Given this list of marker genes GSTA2, BCO2, CYP2E1, DBP, TTR, AFP, BBOX1, OTOP3, PLSCR1, PPM1J, MCAM, CRP, SLC13A1, GPR151, MPP4, CYP1A1, FOXQ1, APOA2, here is a description of the gene set: Genes down-regulated in small intestine tissue from transgenic mice expressing a mutant form of COL13A1, compared to normal controls. species: Mus musculus from publication Tuomisto A, Sund M, Tahkola J, Latvanlehto A, Savolainen ER, Autio-Harmainen H, Liakka A, Sormunen R, Vuoristo J, West A, Lahesmaa R, Morse HC 3rd, Pihlajaniemi T (PMID 19074901) Human Gene Set: TUOMISTO_TUMOR_SUPPRESSION_BY_COL13A1_DN Epithelial cells of mucosal surfaces are critical for maintaining immune homeostasis by aiding in the discrimination of pathogenic and commensal microorganisms and modulating the activities of antigen-presenting cells and lymphocytes. Functional breakdowns resulting in chronic infection and inflammation are associated with the development of hematologic and solid neoplasms for which detailed pathogenetic mechanisms are poorly understood. Mice heterozygous for a transgene Col13a1(del) expressing a mutant collagen XIII developed clonal mature B-cell lineage lymphomas originating in mesenteric lymph nodes (MLN). The tumors were associated with T cells and macrophages. The incidence of disease was reduced 2-fold in transgenic mice raised under specific pathogen-free conditions, suggesting a role for infectious agents. The lymphomas did not express the mutant collagen XIII, indicating that its influence on tumorigenesis was B-cell extrinsic and likely to be associated with collagen XIII-positive tissues drained by the MLN. Studies of the small intestines of transgenic mice showed that the subepithelial basement membranes (BM) were highly abnormal and that they exhibited heightened expression of genes involved in immune responses. These results define collagen XIII-dependent maintenance of the intestinal BM as a previously unappreciated component of immune responses and a critical determinant of cancer susceptibility.